Given this list of marker genes Rreb1, Coro1b, Vil1, Src, Enpp2, Coro1c, here is a description of the gene set: Any process that activates or increases the frequency, rate or extent of lamellipodium morphogenesis. species: Mus musculus Mouse Gene Set: GOBP_POSITIVE_REGULATION_OF_LAMELLIPODIUM_MORPHOGENESIS